Given this list of marker genes PLEKHA5, CCDC191, CRISPLD2, GLIPR1, SCAI, PCDHB9, ST6GALNAC3, PLAG1, SIDT2, ZNF559, EBF2, RFTN2, NSG1, EML1, SUGT1, CHD9, GLS, ELAPOR1, TRMT9B, PRSS35, SETD7, DLAT, ZNF230, ZFYVE28, SCN9A, KPNA4, MT1X, TRAPPC11, CABIN1, ENPP3, LAMC1, NIP7, HGF, PAX3, EFNA4, KLF15, SREK1IP1, HSPB7 (heat shock protein family B (small) member 7), DSE, HFM1, CFAP97, EVA1C, USP49, CUX2, RHBDL2, PEX12, COQ10B, RB1CC1, TMTC4, GRIK2, ATP2A2, PRLR, HBS1L, AQR, SLC16A4, HNRNPA0, ZNF225, TNFAIP6, LIN9, ENOX2, EPHX4, IARS2, HYKK, KL, PRKACB, MACROD2, ATP6V1G1, FAM117B, SLC25A14, SLITRK6, DSCAML1, SLC25A16, KIAA0825, PGAM5, FEM1C, ZNF80, SPTSSB, CEBPB, PRKD1, ARL15, MT2A, OTUD3, RBMS1, PPP1R10, TIFA, SGMS1, AGO2, PON2, ERI2, PDIA6, WWTR1 (NCBI Gene Id 25937), HEPHL1, DCTN5, UST, EIF4B, BPTF, GIGYF2, TRIM60, TRIM22, USP53, KHDRBS3, SCOC, BEND4, C15orf48, ZFP82, TRPM3, GAB1, PPIL3, QKI, NME5, PDE8A, GLE1, ALDH1L2, CELF4, PSMA5, HDX, PRKCE, MAN1C1, BNC1, XPR1, PI15, CDO1, FBXO11, G6PC2, SPDYE3, GPR180, ZNF254, PUS7, SLC7A2, GRAMD2B, BRWD1, CACNA2D1, TIAM1, TLCD5, TRABD2B, FAM98A, WDR17, SLC4A4, LSM8, GPC6, RAPGEFL1, here is a description of the gene set: Genes predicted to be targets of miRBase v22 microRNA hsa-miR-376a-3p, hsa-miR-376b-3p in miRDB v6.0 with MirTarget v4 prediction scores > 80 (high confidence targets). from publication Chen Y, Wang X (PMID 31504780) Human Gene Set: MIR376A_3P_MIR376B_3P studied in species Homo sapiens